The following is a description of a gene set: Germinoma species: Homo sapiens A type of undifferentiated germ cell tumor that may be benign or malignant. Human Gene Set: HP_GERMINOMA, and this is the list of marker genes: MAP3K1, CDH1, PIK3CA, DHH, IGF2, AKT1, SOX9, KEAP1, CTNNB1, FGFR2, OPCML, STS, PRKN, ERBB2, DICER1